Given this list of marker genes INPP5J, MGST3, NEFM, ADARB1, TBR1, SEPTIN9, ZNRF2, MFSD4A, HMGCS1 (3-hydroxy-3-methylglutaryl-CoA synthase 1), BDNF, CLN8, CDK14, ARHGEF25, CCN3, MOBP (NCBI Gene Id 4336), ASIC2, COPRS, CADPS, HSPA1B, ADCYAP1 (adenylate cyclase activating polypeptide 1), NMBR, FAM9A, SYT2, SMAD1, FHL2, NEFH, NPTX1, TUBB2A, MEF2C, SCN1A, CCN2, GARS1, ELAVL2, CCK, PTPRK, STMN1, STMN2, SERPINI1, TXN, OLFM1, APBA2, INA, GSTO1 (glutathione S-transferase omega 1), FHOD3, ASAP1, VSNL1, COL5A2, TPBG, IMPACT, here is a description of the gene set: studied in species Mus musculus from publication McClung CA, Nestler EJ (PMID 14566342) DeltaFosB (a truncated form of FosB) and CREB (cAMP response element binding protein) are transcription factors induced in the brain's reward pathways after chronic exposure to drugs of abuse. However, their mechanisms of action and the genes they regulate remain unclear. Using microarray analysis in the nucleus accumbens of inducible transgenic mice, we found that CREB and a dominant-negative CREB have opposite effects on gene expression, as do prolonged expression of DeltaFosB and the activator protein-1 (AP-1) antagonist DeltacJun. However, unlike CREB, short-term and prolonged DeltaFosB induction had opposing effects on gene expression. Gene expression induced by short-term DeltaFosB and by CREB was strikingly similar, and both reduced the rewarding effects of cocaine, whereas prolonged DeltaFosB expression increased drug reward. Gene expression after a short cocaine treatment was more dependent on CREB, whereas gene expression after a longer cocaine treatment became increasingly DeltaFosB dependent. These findings help define the molecular functions of CREB and DeltaFosB and identify clusters of genes that contribute to cocaine addiction. Human Gene Set: MCCLUNG_DELTA_FOSB_TARGETS_2WK Genes up-regulated in the nucleus accumbens (a major reward center in brain) 2 weeks after induction of deltaFosB, a FOSB splice variant.